The following is a description of a gene set: Mouse Gene Set: GOBP_BONE_MORPHOGENESIS studied in species Mus musculus The process in which bones are generated and organized., and this is the list of marker genes: Cyp26b1, Actn3, Gnas, Tfap2a, Pthlh, Tmem119, Neurog1, Axin2, Npr2, Hoxd11, Rarb, Atf2, Glg1, Scube2, Fgfr3, Atg9a, Sik3, Fgfr2, Scx, Col2a1, Nab1, Twist1, Col10a1, Pax1, Tgfb1, Sp5, Sox9, Zmpste24, Col9a1, Ripply1, Tifab, Nppc, Fgf18, Gli3, Bmpr2, Cst5, Col3a1, Mmp16, Insig2, Pappa2, Bpnt2, Bmp6, Msx1, Mmp13, Dlx5, T, Bmpr1b, Hottip, Rab23, Ext2, Runx2, Mef2c, Pex7, Mmp14, Phospho1, Fosl2, Thbs3, Chsy1, Thbs1, Hoxa11, Acp5, Ripply2, Bmp4 (bone morphogenetic protein 4), Atg9b, Foxn3, Stc1, Col13a1, Cited2, Insig1, Msx2, Megf8, Rara, Nab2, Enpp1, Alpl, Comp, Frem1 (NCBI Gene Id 329873), Serpinh1, Ext1, Has2, Trpv4, Ift80, Foxc1, Nfix, Tgfbr2, Por, Cer1, Mef2d, Dspp, Ifitm5, Ltf, Tmem107, Osr2, Cbs, Fgf4, Hspg2, Matn1, Ihh, Smpd3, Ski, Lrp5, Csgalnact1, Rarg, Carm1, Col1a1, Galnt3, Sfrp4, Col27a1, Cdx1, Trip11, Shox2, Dhrs3, Poc1a, Lrp6, Ltbp3, Inppl1